Given this list of marker genes Jun, Fos, Jund, Junb, Nfatc2, Fosl2, here is a description of the gene set: studied in species Mus musculus Mouse Gene Set: GOCC_TRANSCRIPTION_FACTOR_AP_1_COMPLEX A heterodimeric transcription factor complex composed of proteins from the c-Fos, c-Jun, activating transcription factor (ATF) or JDP families. The subunits contain a basic leucine zipper (bZIP) domain that is essential for dimerization and DNA binding. Jun-Fos heterodimers bind preferentially to a heptamer consensus sequence (TPA responsive element (TRE)), whereas Jun-ATF dimers bind the cyclic AMP responsive element (CRE) to regulate transcription of target genes.